The following is a description of a gene set: studied in species Homo sapiens An anomaly of the form or number of cells in the bone marrow. Abnormal bone marrow cell morphology Human Gene Set: HP_ABNORMAL_BONE_MARROW_CELL_MORPHOLOGY, and this is the list of marker genes: TET2, KRAS, RNASEH2A, WRAP53, MAN2B1, HAVCR2, ACBD6, ALPK1, DUT, NLRC4, LMBRD1, RFX5, CLPB, ASXL1, RFXAP (NCBI Gene Id 5994), NRAS, NOP10, EVC2, SLC46A1, PRKACB, WDR19, TERC, BACH2, RPA1, DPP9, CA2, STN1, TCF3, FYB1, ITK, DDX41, GNE, TBXAS1, LYST, CXCR2, SRP54, PGM3, DKC1, RAC2, TERT, XRCC4, ZCCHC8, PTPRC, IRF2BP2, TCN2, PSMB9, ERCC4, CARD11, STXBP2, MMAA, USB1, SCARB2, IRF8, PRKAR1A, MPL, ANKRD26, MAD2L2, FANCB, SRP72, SRP68, PSTPIP1, CTLA4, IVD, ITCH, GNA14, TYMS, FANCD2, RECQL4, MYH9, STX11, PIGM, FAS, SH2D1A, AMN, IKZF1 (IKAROS family zinc finger 1), LIG4, PALB2, DNASE2, CASP10, HSPA9, FLNA, TP53, TLR8, NAXD, PRF1, RPL26, TBL1XR1, ICOSLG, RUNX1, FARSB, SAMD9, GNAS, EFL1, HPGD, NHP2, SAMD9L, IFIH1, ANAPC1, NBEAL2, SLCO2A1, ATM, MDM4 (NCBI Gene Id 4194), LRBA, UBA1, SH2B3, FLI1, JAK2, KIF15, VPS33A, ADH5 (alcohol dehydrogenase 5 (class III), chi polypeptide), TNFRSF4, RFWD3, RPS14, NBN, SLX4, THPO, PCCB, ATR, FANCE, FANCL, CDIN1, DCLRE1B, ZNF699, GATA1, ACP5, TALDO1, COQ2, RAD51, ELANE, CD28, FANCF, PDCD1, ABCB7, STAT5B, CTC1, SHOC2, SLC7A7, UNC13D, IFNG, FASLG, TNFRSF9, PIGA, ZBTB16, MMAB, KIF23, CUBN, DYNC2LI1, CBL, BCOR, CD27, MRPS7, WAS, SLC19A1, SRSF2, MPIG6B, DHFR, SLC35A1, BRIP1, ZNFX1, CTNS, SP110, FANCI (FA complementation group I), GP9, CCND1, SMARCAL1, PRKACA, ERBB3, GFI1B, LBR (lamin B receptor), MYSM1, NABP1, GLI1, GP1BA, HSCB, RAB27A, ERCC6L2, MTRR, MYC, XIAP, MTHFD1 (NCBI Gene Id 4522), RACGAP1, LPIN2, TCIRG1, GP1BB (glycoprotein Ib platelet subunit beta), NUMA1, SLC30A7, SMARCD2, RTEL1, HOXA11, GATA2, ACD, SEC61A1, EVC, CIITA, RARA, GFI1, RPL18, DNAJC21 (NCBI Gene Id 134218), TNFRSF1B, PCCA, UBE2T, CALR, PML, GALE, GBA1, HLA-DRB1, TGFB1, FIP1L1, ADA2, PARN, OSTM1, SRC, KIT, CXCR4, BRCA2, RFXANK, TNFSF11, COG6, CSF3R, TINF2, CLCN7, SARS2, RAP1B, SBDS, MMADHC, SF3B1, FANCC, SRP19, STAT3, NPM1, JAGN1, FANCA